Given this list of marker genes GNG4, GNG10, GNG7, GNG11, GNGT2, GNB1, GNG5 (G protein subunit gamma 5), GNGT1, GNG13, GNB5, PLCB1, GNB3, PLCB3, GNB2, GNG8, GRIK3, GNG2, PLCB2, GNG3, GNG12, GNB4, here is a description of the gene set: part of: Activation of kainate receptors upon glutamate binding Kainate receptors in the presynaptic neuron are involved in modulating the release of neurotransmitters like glutamate and gamma amino butyric acid (GABA). This activity of Kainate receptors is independent of ionic fluxes through the channel. Homomeric kainate receptors containing GRIK3 are shown to be involved in this process. Kainate receptors in these neurons bind G-protein coupled receptors that activate phospholipase C which eventually triggers the release of Ca2+ from the intracellular stores. The released Ca2+ further initiates the fusion and release of vesicles containing the neurotransmitter. Reactome Pathway: Presynaptic function of Kainate receptors species: Homo sapiens